The following is a description of a gene set: Mouse Gene Set: GOMF_GALACTOSIDE_BINDING studied in species Mus musculus Binding to a glycoside in which the sugar group is galactose., and this is the list of marker genes: Lgals4, Lgals9, Slc2a3, Lgals2, Glb1, Gla